Given this list of marker genes PCDH19, SMARCAD1, SYT11, ELF4, NME4, LRIG1, NRAS, GCNT4, IGF2BP3, NKD1, PRTG, COL3A1, IGF2BP1, STK40, ADAMTS8, HIC2, MXD1, APBB3, C14orf28, PBX3, NKAPD1, AKAP6, CBX2, LINGO1, CBL (Cbl proto-oncogene), SPINDOC, OPRM1, ZC3H3, FZD4, ABCB9, UHRF2, ELP1, E2F6, SMAP2, NCOA1, CYP19A1, TGFBR1, SCN5A, ACVR1B, SNX16, GNG5, LRIG2, PALD1, EPRS1, SSH1, EXOC3L1, SCUBE3, ATOSB, ADRB2, DOT1L (NCBI Gene Id 84444), SEMA4G, WNT1, LGR4, HAND1, CCR7, ITGB3, DCAF15, ULK2, SPRYD4, AMMECR1L, TRIM67, HOXD1, ZNF354A, NAPEPLD, RIMOC1, CPM, RALB, DLGAP4, CLP1, ATP2B3, SCD, NSMCE2, GNPTAB, NME6, LIMD2, KLHDC8B, TMEM121B, SEMA3F, DPF2, GABBR2, PPP1R15B, COL14A1, RUFY3, PDPR, RDX, CPD, CBFA2T3, TRAPPC1, ZBTB39 (zinc finger and BTB domain containing 39), NLK, RAB15, UNC5A (unc-5 netrin receptor A), MAP4K3, CYP46A1, PHF8, CCDC71L, COL24A1, BACH1, SLC35D2, SOWAHA, C15orf39, OSMR, PARD6B, ARHGAP28 (NCBI Gene Id 79822), DCLRE1B, ERCC6, CLUH, SLC25A27, TMPRSS2, ZNF710, NCOA3, PRDM2, STX17, SOCS1, PRPF38B, PLPP6, GAS7, MEF2D, KLF9, NOVA1, MYO1F, CGNL1, HOXC11, COIL, DMD, LIN28B, GPR137, ARID3B, SFSWAP, TSC1, KATNBL1 (NCBI Gene Id 91186), KLHL13 (NCBI Gene Id 90293), GAN, EZH2, DCUN1D2, ATP2B1, IL13, ZNF282, WDR37, DYRK1A, ZNF740, PPP1R16B, CTNS, IGSF1, DLST, CLASP2, ARRDC4, LSM11, ANKRD49, PRRX1, RPUSD3, KIF21B, ABCC5, LRATD2, LTN1, SLC25A18, CHD4 (NCBI Gene Id 1108), MAPK6, PGM2L1, GOLT1B, SEMA4C, MIB1, ANKFY1, TSPAN18, SLAMF6, DDN, IKBKE, EFHD2, PAPPA, ELOVL4, NIPA1, PLXND1, CDIN1, GNAL, IGF2BP2, LRRC17, CCNJ, FRAS1, IGDCC3, HOXA1, SPATA2, RASL10A, PCGF3, RFX6, AAK1, BIN3, FBXL12, E2F5, USP6, DDI2, RRP1B, COL5A2, CLDN12, TUSC2, ZBTB5, PLEKHH1, MGAT4A, SCRT2, RASL10B, MECP2, PIGA, RPS6KA3, SLC26A9, IGDCC4, NDST2, SEMA4F, SNAI3, ERGIC1, NXT2, STX3, TRIM41, PCYT1B, B3GNT6, MEIS3, CPSF4, SOX13, DDX19A (DEAD-box helicase 19A), ARPP19, GALNT1, GALNT15, ZNF318 (zinc finger protein 318), PLEKHG6, USP38, CPEB2, HSPA14, YOD1, VCF1, GALE, CACFD1 (NCBI Gene Id 11094), ZNF280B, SP8, DCUN1D3, XKR8, OSBPL3, INTS2, HMGA1, SLC6A1, KLK10, RSPO2, ZNF644, MYCBP, ATP2A2, RNF7, SYT7, MED8, SLF2, HTR4, LCORL, CERCAM, PAK1 (p21 (RAC1) activated kinase 1), HMGA2, NAP1L1, AHCTF1 (NCBI Gene Id 442770), GGA3, ZNF512B, ZFYVE26, NAA30, DPP3, PDGFB, ACSL6, TMED5, KMT2E, IQSEC2, ETNK2, SLC25A24, KCTD21, CEP120, CHRD, STIMATE, ADRB3 (adrenoceptor beta 3), POLR3D, DTX2, LIN28A, LMX1A, MASP1, RAB11FIP4, TNFRSF1B, PLA2G15, C8orf58, CDV3, FASLG, DHX57, DCX, MDFI, RASGRP1, STAT3, PARP6, TTL, RNFT1, SLC20A1, DVL3, COL1A1, DIAPH2 (diaphanous related formin 2), CACNG4, DOCK3, TIMM17B, SCN4B, EDA, SNN, MIEF1, PYY2, BLOC1S6, TBKBP1, MGLL, PTPRU, TRIM71 (tripartite motif containing 71), BCL2L1, ARHGEF15, BZW2, AP1S1, VANGL2, GOLGA7, FNDC3A, ACVR1C, FIGN, PPP1R12B, FAM118A, SLC16A14, RNF20, RAB40C, TEAD3, TRABD, UFL1, DAGLA, SGCD, EGR3, ADAM15, MAP4K4, TBX5, DDX19B, NHLRC3, IRS2, SIGMAR1, CPA4, BEGAIN, RANBP2, PLA2G3, RGS16, CRY2, NFASC, CD200R1, EDEM3, SOCS4, EIF4G2, COL1A2, SLC5A6, KCTD17, ZNF362, RICTOR, RNF5, CEMIP2, TAF9B, PNKD, ANKRD28, LRIG3, ZNF583, BZW1, CCNF, PLD3, KIAA0930, RBM38, FGF11, USP32P2 (NCBI Gene Id 96541), ACER2, PBX2, CDC25A, GDF6, DKK3 (NCBI Gene Id 51583), ARHGAP20, ZCCHC3, SLC4A4, USP32, BRWD1, RDH10 (retinol dehydrogenase 10), ABCC10, RPUSD2, NRARP, SMARCC1, PLAGL2, TOB2, PUDP, CDH22, ADAMTS5, NUP98, RIOK3, NPHP3, SLC8A2, TTLL4, PLCXD3, FNIP1, here is a description of the gene set: Genes having at least one occurence of the motif CTACCTC in their 3' untranslated region. The motif represents putative target (that is, seed match) of human mature miRNAs hsa-let-7a, hsa-let-7b, hsa-let-7c, hsa-let-7d, hsa-let-7e, hsa-let-7f, hsa-miR-98, hsa-let-7g and hsa-let-7i (v7.1 miRBase). Human Gene Set: CTACCTC_LET7A_LET7B_LET7C_LET7D_LET7E_LET7F_MIR98_LET7G_LET7I species: Homo sapiens